The following is a description of a gene set: Human Gene Set: REACTOME_KERATAN_SULFATE_BIOSYNTHESIS species: Homo sapiens Keratan sulfate biosynthesis, and this is the list of marker genes: B4GALT1, ST3GAL6, CHST5, ST3GAL3, OGN, CHST2, B4GALT2, B3GNT7, FMOD, SLC35D2, B4GALT6, B3GNT2, CHST6, PRELP, ST3GAL4, OMD, B3GNT3, B4GALT3, ST3GAL2, ACAN, B4GALT4, B3GNT4, LUM, CHST1, KERA, ST3GAL1, B4GAT1, B4GALT5